The following is a description of a gene set: part of: Extra-nuclear estrogen signaling studied in species Mus musculus Reactome Pathway: Estrogen-stimulated signaling through PRKCZ This event has been computationally inferred from an event that has been demonstrated in another species.<p>The inference is based on the homology mapping from PANTHER. Briefly, reactions for which all involved PhysicalEntities (in input, output and catalyst) have a mapped orthologue/paralogue (for complexes at least 75% of components must have a mapping) are inferred to the other species. electronically inferred by orthology from the curated human pathway, and this is the list of marker genes: Pdpk1, Hras